Given this list of marker genes AK5, GPD1L, OGDH, NDUFB8, IGF1, RAB23, PAICS, PDE2A, PPT2, ICMT, PGM1, NDUFB3, ACACA, ATPSCKMT, NDUFA8, FBP1, MAPDA, PAPSS1 (NCBI Gene Id 9061), DMAC2L, ELOVL6, TPK1, ENTPD1 (NCBI Gene Id 953, ectonucleoside triphosphate diphosphohydrolase 1), TP53, ATP5ME, HSD17B12, NPR2, FIS1, ACSM2A, DERA, ACSL3, NDUFV3, NUDT18 (nudix hydrolase 18), ACSS2, MTHFD2L, NUDT19, PRPSAP1, VNN1, NDUFA1, GUCY2C, NDUFA2, PGAM1, ADCY3, ME2, NPPB, ACP3, PGK1, ACLY, NAMPT, NT5C, PDHA1, BPNT1, MLXIPL, NDUFB7, NUDT1, TTR, PPARA, NDUFS5, DLAT, TIGAR, MVD, PFKM, TPST2, FAR2, ATP5F1A, ENO4, ACOT7, PFKFB1, FHIT, PDE9A, GUCA1A, URAD, NDUFA7, CTNS, GCK, GMPS, HTR2A, TSPO, PGD, PARG, ELOVL3, GAPDHS, COX11, GART, OGDHL (NCBI Gene Id 55753), PANK2, ACSL4, MT-ND3, NUDT5, IDO2, SHMT1, MT-ND4L, SDHA, DIP2A, FLCN, OLA1, ATP7A (NCBI Gene Id 613259), IL4, RPE, PDK1, MYH8, SLC25A12, ADA2, PRKAA2, MT-ND2, PRTFDC1, MFN1, MYH4, NUDT8 (NCBI Gene Id 50602), ELOVL2, ENO1, ACACB, BPGM, PDE5A, HACD1, GALK1, MYH3, SULT1A3, ACSS1, NME3, NUDT12, SLC4A4, ATP5MC2, ACAT1, ENO2, RD3, ADCY10, PDE4C, ACOT8, FOXK2, PID1, PPCDC, TREX1, ADCY2, SULT1A1 (NCBI Gene Id 6817), NPPA, AMPD3, ALDOB, LDHC, NME7, SARM1, ATP5MF, PPAT, PSEN1, PIPOX, ELOVL1, NME4, ALDH1L1, NME2P1, PDHA2, GUK1, MTOR (mechanistic target of rapamycin kinase), FKRP, TMSB4X, HDAC4, SULT1C4, PFAS, SUCLG1, NDUFS8, ACSBG2, DCAKD, ENTPD4, NDUFA5, PANK1, STAT3, SAMHD1, NDUFS1, MT-ND1, NME2, NAPRT, TREM2, ACSF3, ACOT11, PC (pyruvate carboxylase), AFMID, NUDT10, TP53I3, LDHA, HMGCS1, PRKAG1, FITM2, NDUFA12, NDUFA3, ACSM2B, ATP5F1E (NCBI Gene Id 514), TGFB1, AMPD2, CLPX, FAR1, NUDT9, NPR1, DNAJC30, UQCC3, ATP5MK, PRKAG3, ACOT4, NMNAT3, MT-ND4, SLC22A11, HMGCS2, AADAT, FMO2, TECR, MIR675, CARD11, NDUFB2, SLC16A9, ENPP4, NUDT16, NDUFA13, SLC2A9, NDUFB10, LDHB, TALDO1 (NCBI Gene Id 6888), NT5C2, MT-ATP6, DLD, KYNU, ATP5F1C, NMRK1, SELENON, NDUFA10, THEM5, TJP2, GCDH, PRKAG2, ATP5MG, EIF6, GUCA1ANB-GUCA1A, PDE1A, DLST, NDUFS4, HIF1A, PANK3, DPYD, GUCY1A1, ADPGK, ADSL, ACSM1, GNAI3, DGUOK, NDUFB11, PDK3, IFNG, SLC27A2, PMVK, HK1, NDUFB1 (NADH:ubiquinone oxidoreductase subunit B1), LRRK2, ADCY4, NADK2, DLG2, APP, PDE10A, AK3, GTPBP1, KAT2B, GDA, BCKDK, NDUFB4 (NCBI Gene Id 727762), ABCG2, HAAO, ITPA, ACSM5, FAM3A, MLST8, SLC25A11, VPS9D1, ACSM6, AK2, PTGDR, EPHA2, G6PC1, EFL1, COL6A1, CBR4, GPAM, ATP1B1, TDO2, NMRK2, NADK, DGAT1, AK1, ATP5PB, G6PD, GUCY1A2, SULT2A1, MLYCD, PGLS, LACC1, HPRT1, HSPA1B (NCBI Gene Id 3304), ALDOA, HKDC1, FOXK1, MT-ATP8, MCCC2, TAFAZZIN, KDM1A, RPTOR, PRPSAP2, ACTN3, PDE8B, SULT1E1, GIT1, ADSS2, ENPP1, NUDT3, SLC25A13, HMGCR, NDUFB5, NME6, HSPA8, ATP6V1A, IDH1, ATP6V1B1, NDUFV2, NT5E, NDUFA6, PGM2, SLC4A1, PDE7A, BEND3, DHTKD1, BLOC1S6, ADCY8, MDH1, GPD1, NME9, ADCY9, ME1, NUDT15, MAP2K1, PKLR, ELOVL7, GPI, HINT1, ACSL1, OGT, PDK2, PKM, PDHX, MACROH2A1, NADSYN1, RORA, STOML2, HK2, MAGI3, PGAM2, MPP1, HK3, SULT1B1, NOCT, NMNAT1, SULT1A2, ABCC6, PNP, ENSG00000293349, NDUFB6, ADCY1, MT-ND6, PDK4, TPST1, GIMAP7, ASPDH, BCL2L13, NT5C1A, ACO1, MDH2, NUPR1, PARP1 (poly(ADP-ribose) polymerase 1), ZBTB7A, SULT1C3, ACSF2, ATP6V1B2, ABHD14B, SDHB, SDHC, SULT2B1, INS, NDUFV1, MT-ND5 (mitochondrially encoded NADH:ubiquinone oxidoreductase core subunit 5), GNMT, RPEL1, PGK2, ACSBG1, GPAT4, ATP5F1B, ADCY7, CARMIL1, PRXL2C, BAAT, APRT, PFKFB3, DNPH1 (NCBI Gene Id 10591), ATP6V0C, CACNB4, OARD1, NOX1, NDUFAB1, BAD, TPI1, HSD17B4, ACMSD, NME5, NUDT4, ACOT12, PFKL, SLC25A22, NME1, ELOVL5, ELOVL4, DLG1, ACOT2 (acyl-CoA thioesterase 2), SUCLG2, GCKR, NDUFS6, QPRT, PRKACA, GOT1, PINK1, IMPDH2, ATP5F1D, MMUT, GLYAT, IDO1, MDH1B, MPC2, GUCY2F, ACSL6, SULT1A4, NUDT2, PRKN, ACSM4, NUDT11, XDH, PDE4B, ATIC, PRPS1, FIGNL1, GPD2, NDUFC2, GUCY1B1, LRGUK, NDUFA11, PTHLH, PDE7B, NUDT7 (nudix hydrolase 7), GOT2, PRPS2, ATP5PF, NMNAT2, GAPDH, SRC, NDUFS7, ADSS1, SDHD, PPCS, PPP2CA, SIRT6, ADA, PPT1, ACOT1, SLC25A18 (solute carrier family 25 member 18), MTAP (methylthioadenosine phosphorylase), TRIM63, RHOQ, PGAM4, GMPR, OPA1, ACOT9, RPIA, ABCC9, SLC22A12, PTH, MACROD1, PAPSS2, PDE4D, IDH2, NUDT17, COASY, AMPD1 (adenosine monophosphate deaminase 1), MTCH2, ZBTB20, ACSM3, RAN, PFKP, SHPK, HACD2, TKT, FASN, GMPR2, H6PD, P2RX7, HSPA1A, NDUFS2, PDE8A, AASS, SPHK2, MFSD8, MACROD2, UCHL1, LIPA, ACOT6, MYH6 (myosin heavy chain 6), ADCY6, UCP2, DCXR (NCBI Gene Id 51181), RBKS, ATP5PD, CD38, NUDT13, NCOR1, PFKFB2, IER3 (immediate early response 3), ATP1A2 (NCBI Gene Id 93186), PRKAA1, ATP5F1EP2, SLC4A7, NDUFS3, ARNT, NDUFC1, ANTKMT, ATP5PO, ABCD1, SLC25A25, ENO3, ATP5MJ (NCBI Gene Id 9556), NDUFB9, INSR (insulin receptor), MTHFD1, LETMD1, SUCLA2, DNM1L, SLC17A3, ATP5MGL, ACSL5, ADK, MVK, IMPDH1, ADCY5, JMJD8, ATP5MC1, DGAT2, SLC17A1, NUDT4B, ATP5IF1, ARL2, PANK4, NT5C1B, PRPS1L1, GUCY2D, ALDH1L2, DDIT4, ALDOC, ATP5MC3, DCK, KMO, OXSM, MCEE, NDUFA9 (NCBI Gene Id 4721), NNT, CBFA2T3, AK4, NPPC, ENPP3, PDHB, VCP (valosin containing protein), HTD2, ENTPD7, EP300, SLC2A6, PDE4A, CROT, CASK, SNCA, MYH7, here is a description of the gene set: The chemical reactions and pathways involving a purine-containing compound, i.e. any compound that contains purine or a formal derivative thereof. studied in species Homo sapiens Human Gene Set: GOBP_PURINE_CONTAINING_COMPOUND_METABOLIC_PROCESS